Given this list of marker genes ADH4, SLC20A1, IFIT3, DDHD1, AIFM1, RRM2, F2R, MAPK10, TRIM21, MED12L, SHARPIN, IFT80, PTP4A3, PON2, ICAM1, ONECUT1, MFN2, SHISA2, SEMA6A, ANKRD13C, BTG3, ACTG1, UBQLN4, CRLF1, CHMP1A, FGF21, CUBN, SMTNL1, RPL19, CATSPER2, BET1L, ABRACL, DBNL, AP3D1, PNOC, FBXO21, KPNA2, RAB11B, NR1I2, HELB, HMCES, HCST, PURB, CDH13, PPP4R3A, SCAMP2, RAB33B, RUFY3, STARD5, CTNND1, CREB3L4, MARCHF6, CEP55, AGR2, ALDH3A2, KCTD2, SIRT7, THBS4, SPMIP10, SLC10A3, GBP6, PAFAH1B1, CCNG1, RGS2, SFRP5, RALB, ARHGAP12, PEAK1, RBL2, LPCAT1, STEEP1, CLCN4, ANKIB1, SRI, PDHA2, TCF19, NME2, NCKAP1L, MYL12B, SLC41A1 (NCBI Gene Id 254428), TJP3, PHTF1, TMEM123, CDH1, GPANK1, RNF4, DDX39B, GMIP, HRH4, CP (NCBI Gene Id 1356), RYR3, HAUS8, ANAPC13, CHADL, CDR2L, KLHL25, EML6, UBAP1, IRF9, FBN2, GON4L, SOX14, CROT, OXR1, MYF6, SCN3A, AP3M2, FBXO22, TUBB4B, CMPK1, LPGAT1, SUMF1, POLR3C, NANOS1, SLC37A1, PPP6C, MSANTD2, SMC5, MRPS6, XRCC4, NCOA2, LYN, FANCI, KDF1, TMEM140 (NCBI Gene Id 55281), UTY, TAF1A, CYP17A1, PRSS16, MYCN, FNBP4, MYO9B, SEC62, SH3BP2, DOK2, NTSR2, INSM2, EIF3F, TASOR2, DPP3, PPP1R21, ANGPTL1, MRPS21, ZFHX4, COL22A1, LIPC, TBC1D20, DXO, ATP4B, ATL3, CLDN8, CCDC71, CHD8, LGI4, CDADC1, PDPK1, HTR3B, RPS9, GIGYF1, ACTN2, RNH1, STYX, SYAP1, CPSF7, MYLIP, TRIR, PMM2, CCNB1IP1, ANXA3, FUS, FPGS, GJB4, MTF1, TNIP2, VNN1, HMOX2, SERHL2, CNOT6L, SSNA1, ERAP1, JPT1, GJA4, SGCG, SYF2, BPIFB1, TRAPPC2, MSL3, MBTPS1 (membrane bound transcription factor peptidase, site 1), TDRD3 (tudor domain containing 3), MAB21L1, FRZB, C9orf40, TMEM131L, GLRA3, PLA2G2E, NRBP1, EI24, CHGA, POPDC2, DERL2, here is a description of the gene set: Human Gene Set: GSE32128_INOS_DEPENDENT_VS_INOS_INDEPENDENT_ACTIVATED_TCELL_DN Genes down-regulated in T cell activation mechanism that was NOS2 dependent versus NOS2 independent activation. Comparison of two Chlamydia-specific CD4 T cells that are dependent on iNOS to terminate Chlamydia replication in epithelial cells to two Chlamydia-specific CD4 T cells that are iNOS-independent: Chlamydia trachomatis urogenital serovars replicate predominately in epithelial cells lining the reproductive tract. This tissue tropism poses a unique challenge for the host immune system and vaccine development. Studies utilizing the Chlamydia muridarum mouse model have shown that CD4 T cells are critical and sufficient to clear primary genital tract infections. In vitro studies have shown that CD4 T cells terminate the infection in epithelial cells by up regulating epithelial iNOS transcription and nitric oxide production via IFN-gamma and T cell-epithelial cell interactions mediated by LFA-1-ICAM-1. This mechanism however is not critical as iNOS-deficient mice clear infections normally, and IFN-gamma deficient mice clear 99.9% of the infection with near normal kinetics. We recently showed that a subset of Chlamydia-specific CD4 T cell clones were able to terminate replication in epithelial cells using a mechanism that was independent of iNOS and IFN-gamma. That mechanism did not require physical lysis of infected cells, but instead required T cell degranulation. In this study we advanced that work using gene expression microarrays to compare CD4 T cell clones that are able to terminate epithelial replication via an iNOS-independent mechanism to iNOS-dependent CD4 T cell clones. Micro array experiments showed that Plac8 was differentially expressed by the T cell clones having the iNOS-independent mechanism. Plac8-deficient mice had significantly delayed clearance of C. muridarum genital tract infections, and that the large majority of Plac8-deficient mice treated with the iNOS-inhibitor N-monomethyl-L-arginine (MLA) were unable to resolve a C. muridarum genital tract infection over 8 weeks. These results demonstrate that there are two independent and redundant T cell mechanisms for clearing C. muridarum genital tract infections; one mechanism dependent on iNOS, the other mechanism dependent on Plac8. While T cells subsets have been defined by cytokine profiles, there are important subdivisions by effector functions, in this case CD4Plac8. species: Homo sapiens from publication Johnson RM, Kerr MS, Slaven JE (PMID 22238459)